Given this list of marker genes St6gal1, Ugcg, Lman1l, H2-Q4, Sdc1, Bet1l, Gga1, Sost, Golt1a, Cav1, Vps37c (NCBI Gene Id 107305), Bicd2, Man2a1, Tmf1, Ccdc88b, Macf1, S100a1, Rab40c, Gorasp1, Hs6st2 (heparan sulfate 6-O-sulfotransferase 2), Golga1, Atp6v0a1, Plpp3, Fut8, Cyp2e1, Creld2, 4930402F06Rik, Axin1, Sipa1l3, Cabp1, Ubxn2b, Gcnt4, Nlrp5, Mphosph9, Clstn2, Tgm4, Galnt18, Prmt5, Yipf5, Slc39a9, Vipas39, Smpd3, Hs2st1, Zfp622, Chek2, Arap1, Syt1, Scamp1, Rab18, Dach1, Lrp2, Fat2, Man1a2, Fam241a, Pals1, A3galt2, Ftcd (NCBI Gene Id 14317), Smo (NCBI Gene Id 319757), Gorasp2, Zdhhc18, B3gnt3, Sncg, Crhbp, Atp8b5, Copg2, Ndst3, Pacsin2, Abca5, Zdhhc7, Atp11a, Cul3, Pcsk4, Scrg1, Golga5, Rsad2, Cd14, Dynap, Clec16a, Ap1s3, H2-M10.3, Gigyf2, Slc66a2, Map2k1, Fam20c, Slc39a7, Srgn, Sdc4, Rab11a, Abca12, Tmed10, Dhcr24, Pde9a, Atp2c1, Mapk1, Nedd4l, Ap1g2, Ndst1, Rab36, Tnfrsf1a, Pick1, Rab6b, Ptprn, Cd33, Ireb2, Plscr2, Tmed11 (NCBI Gene Id 67366), Clvs2, Clcn4 (NCBI Gene Id 12727), Creb3, Zdhhc3, Yipf7, Cd3e (NCBI Gene Id 12501), Otof, Syne1, Nfe2l2, Mal, Fes, H2-T22, Nat8f1, Itm2c, Slc29a3, Tlr6, 1810055G02Rik, Nedd4, Commd9, Apoo, Fam3c, Cd74, Pgap3, Tppp, Clasp1, Nlrp3, A4gnt (alpha-1,4-N-acetylglucosaminyltransferase), Fgf7, Bpnt2, Atp7a, Ccn2, Glt8d2, St6galnac6, St3gal6, Tpte, Ache, Rnd3, Dynlt1b, Six5 (NCBI Gene Id 20475, sine oculis-related homeobox 5), Hs6st1, Mgat2, Pycard, Arl5a, Rab31, Tbc1d4, Map6, Mydgf, Sprr1b, Atl1, Ap3m2, B4galt2, Col26a1, Otor, Gpr108, Pld4, Ddhd2, Ap1s2 (NCBI Gene Id 68960), Aoc3, Dnajc5, Gfy, H2-Q7 (NCBI Gene Id 15018), Ergic1, Vamp5, Atp1a3, Cux1, Dbi, Cptp (ceramide-1-phosphate transfer protein), Prkg1, Taf11, Galnt2, Ppp2r3c, Cracr2a, Perp, Fam20a, Rab33a, Scfd1, Glg1, Myrf, Vamp4, Acsbg1, Mapkap1, Arfgap3, Cdh1, Fgd5 (NCBI Gene Id 232237), B3gnt6, Pea15b-ps, Golga7, Golt1b, Fam114a1, Pla2g4a, Scamp4, Flna, Cldn20, Atat1, Smad6, Capn8, Cav2 (NCBI Gene Id 12390, caveolin 2), Rab40b, Ext1, Rab7b, Sec1, Atp1a1, Rab14, Mmgt2, Golgb1, Usp33, Ap3b2, Gnai3, Mgat4c (MGAT4 family, member C), Mif4gd, Selenoi, Copa, Kif20a, Rab2a, B4galnt1, Rit2, Serpina1c, Chst12, Ap1s1, Smn1, B3gat2, Ccdc170, Chic2, Nbn, Fktn, Stx8, Pkd1, Lrrk2 (NCBI Gene Id 79409), Itm2a, Paqr8, Trappc12, H2-Q1, Rab34, Ms4a6b, Ms4a4b, Rab11fip5, Raf1, Glt8d1, Tas1r3, Gkap1, Rps12, Plekha8, Gal3st2, Gosr2, B3galt2 (UDP-Gal:betaGlcNAc beta 1,3-galactosyltransferase, polypeptide 2), Evi2a, Syt11 (NCBI Gene Id 99745), B3gnt2, Man1c1, Rnf183, Golga7b, Pthlh, Stx16, Scamp3, Zdhhc8, Rhbdd2, Snap25 (synaptosomal-associated protein 25), Chst4, Gimap8, Furin, Entpd5, Arl2, Mmp24, Cog1, Ap1b1, Fyco1, Plekhb1 (NCBI Gene Id 27276), St8sia5, Pex5, Steap2, Rabgap1l, Atp8b2, Tapbp, Pdxdc1, St3gal5, Snx9, Slc26a9, Dnmbp, Rtn3, Dnm1l, Pclo, Slc2a1, Mapk15, Creb3l4, H2-Q2 (histocompatibility 2, Q region locus 2), Mapk3, Rac1, Trappc9, Dnaaf2, Tpst1, Wscd1, Galnt15, H1f0, Wscd2, B4galt7, Spry1, Syt17, Clstn1, Ptges2, H2-M11, Il17rd, Scap, Sgce, Rab1b, Phf7, Aph1b, Marchf1, Extl1, Tbc1d14, Barx2, Gcc2, Cep85, Pcnt, Rab30, Gbp2b (NCBI Gene Id 677276), Serpinb9g, Tgtp2, Chac1, Erc1, Emp2, Tmem98, Gabarapl1, Yipf1, Sppl2b, Slc35a4, Crhr1, Mdga1, Myo1b, Traf3ip3, Ero1a, Mgat1, Jakmip2 (janus kinase and microtubule interacting protein 2), Drd2, Mttp, Zdhhc12, Cbl, H2-T10, Neo1, Nsg1, Mplkipl1, Slc35a3, Pphln1, Arfgap1, Pkd2, Elapor1, Ms4a4c, Lfng, A4galt, Rassf2, B3galnt1, Caln1, Wls, St3gal1, Lmtk2, Tmem30a (transmembrane protein 30A), Myo6, Gask1b (NCBI Gene Id 99844), Chst8, Camk1g, Ubac1, Lyn, Pdgfrb, Fmnl3, Arf6, Rab32, Osbp, Dennd4b, Cop1, Ccdc88a, Rab27b, Trrap, Smpd4, Tvp23b, Birc6, Ppp1r15a, Fgfrl1, Slc35b2, Slc18a3, Tex261, Hs3st5, Nagpa, Vti1a, Cdipt, Chrna3, Slc35c2, Slc24a5, Pkmyt1, Ap1m1, Kif13a, Fut7, Fgfr4, Acp3, Nsfl1c, Ermap, Synrg, Trappc1, Creb3l2, Gpr107, Sec14l1, Kdr, Abcb11, Bcl9, Hdac5, Uxs1, Wdr44, Nedd9, Nmt2, Galntl6, Large2, Gcnt7, Tenm1, Agtrap, Dync2h1, Ndfip1 (NCBI Gene Id 71674), Bicd1, Trappc3l, Sdf4, Serinc5, Paqr4, Yes1, Rab1a, Slc35b3, Nsg2, Chst11, Tmc6, Rasip1, Cog2, Capn2, Lman2l, St6gal2, Atr, Stc2, Gbp4, Rab11fip4, Ndrg2, B4gat1, Inpp5e (inositol polyphosphate-5-phosphatase E), Vamp2, Zdhhc6, Hpd, Ago2, Pacsin3, Galnt17, Optn, Akt3, Dnm2 (NCBI Gene Id 13430), Man2a2, Galnt10, Mapre1, Mettl3 (methyltransferase 3, N6-adenosine-methyltransferase complex catalytic subunit), Serpinb9h, Drd4, Cd2ap, Garin3, Scamp2, Igfbp1, Usp6nl, AU040320, Arhgap21, Ms4a6c, Baiap3, Ap1m2, Garin1b, Asap2, Mmp14, Dpy30, Atp9b, Dym, Pomgnt1, Cog7, Nat8f3 (NCBI Gene Id 93674), Cept1, Gad2, Slc30a6, Rab27a, Pikfyve, B4galt6, Mmd, Rock1, Tsnax, Tjap1, Slc2a4, Srebf2, Sulf2, Jakmip3, Ric1, Gnpnat1, Golm2, Mansc1, Alx1, Ldlrad4, Rab21, Fzd8, Nat8f2, Serpinb9c, Grn, Steap4, Cand1, B3galt6, Mmel1, Clcn5, Aco1, 5730455P16Rik, Sntb2, Ddx54, Sgms2, Stk25, Bace1, Abca6, Bet1, Chst9, Nsf, H2-D1, Copz1, Napepld, Ahsg (NCBI Gene Id 11625), Angptl3, Mta1, Marchf8, Sppl3, Copb1, Camsap2, Ift20, Clta, Zdhhc25, Nubp1, Abcc4, Ipo5, Cit, Kifc3, St8sia3, Prkce, Uso1, Arf2, Pdgfra, Pld1 (phospholipase D1), Selenoh, Fzd5, Cimap3, Alkbh5, Acbd3, Gba2, Cd44, Chrm2, P3h2, Ajuba, Pik3r1, Zfpl1, Atg9b, Gpr89, Ift57, Gnai1, Wasl (WASP like actin nucleation promoting factor), Cln3, Cfp, Gper1, Clspn, Agrn, Vps52, Gdf15, Gdi2, Rheb, Prnp, Amfr, Slc35e3, Srcap, Txndc8, Avpr1b, Trappc6a, Gas8, Dpp7, Inpp5k, Mtor, Scara3, Fndc3a, Blzf1, Chst10, Ergic3, Zdhhc14, Fgfr2, Syndig1l, Slc30a8, H2-Ab1, Trim23, Atf3, Vps45, Cdk13, Zdhhc19, Cabp7, H2-M2, Ptch1, Rab12, Pcsk7, Klhl20, B3galt5, Syn1, Vcpip1, Gcnt2, Chsy1, Nbea, Asic1, Itga5, Unc13b, Aqp2, Gbp2, Pi4k2a, Gcc1, Zfp148, H2-M9, Iigp1, Adcy3, Akap9, App, Pidd1, Stk24, Plekha3, 4933434E20Rik, Gpc5, Pisd, Garin4, Fut2, Ece1, Proc, Pld6, Cpe, Trip10, Fv1, Ptgfrn, Tom1l1, Rab33b, Alb, Gpr143, Plekhm3, Zfyve1, Ccdc91, Slc35c1, Mgat5b, Zdhhc21 (NCBI Gene Id 68268), Ticam2, Gba1, Ap4b1, Clip3, Wdr11, B4galt5, Zdhhc17, Ncs1, Notch2, Cul7, Obsl1, Ap3m1, Fasn, Ece2, Tmem132a, Apoa5, Tmco1, Wipi1 (NCBI Gene Id 74799), Gbgt1, Cd40lg, Rab9, Rapsn, Picalm, Slc35d2, Chst1, Zg16, Pkdcc, Necab3, Cltb, Slc30a7, Ndst4, H2-Q6, Lrp6, Serpinb9, Tmem30c, Sla2, Panx2, Tpst2, Cfap410, Csgalnact1, Tmed9, Usp32, Whamm, Rnf128, Spire1, Tmed2, Slc11a2, Azin2 (NCBI Gene Id 242669), Vcam1, Trim3, Kdelr3, Prkn (NCBI Gene Id 50873), Ap3s2, Vps13b, Ehf, Rab7, Mgat4b, Gal3st3, Itm2b, H2-M10.6, Notch1, Dop1b, B2m, Golga2, Tmed5, Tcp1 (NCBI Gene Id 435546), Apc2, Plod2, Tm9sf4, Litaf, Galnt13, Prcd, Vegfa, Fzd9, Pde3b, Gga2, Itfg2, Tmed6, Glyctk, Tmed3, Lmtk3, St6galnac4, Ggnbp1, Slc30a1, Trpm4, Slc22a13, Arcn1, Slc35g2, Postn, Glce, Hck, Arfip2 (NCBI Gene Id 76932), Hepacam2, Dlg1, Phex, Mapk8ip3, Chst14, Tmem230, Nucb2, Olfm3, Abcc5, Gask1a (NCBI Gene Id 245050), Slc16a13, Ei24, Fam20b, B3galnt2, Msln, Abcb1b, B3gat3, Cst7, Atp8a2, Zdhhc11, B4galnt2, Pofut2 (NCBI Gene Id 80294), Atg9a, Chpf, Hdac3, BC004004, Egfr, Hhat, Tgtp1, Leprot, Tepsin, Galnt6, Tnks2, Sde2, Large1, Gal3st1, Acer3, Hspg2, Ykt6, Cdk20, Fut1, Pmf1, Limk2, Rab8a, Plod1, Pld3, Xylt1, Dclre1c, Lgr5, Dnaaf6rt, Atp8b3, Arl1, Trim7, Slc9a8, Spint2, Zdhhc24, Ap3b1, Bok, Angel1, Resp18, Lpcat2, Il12b, Abca7, Map6d1, Emid1, Cep128, Pmel, Kdelr1, Selenom, Gnaq, Hook3, Nos3, Ganab, Trappc2, H2-M10.2, Gabarap, Fgd1, Vps41, Mpig6b, Atp8b1, Selenok, Rab29, Rnf125, Coro7, B4galt4, Zdhhc23, Cdh15, Pitpnb, Ap4s1, Copg1, Pi4kb, Lztr1, Galnt3, Plagl1, Gpc4, Ptgs1, 4930568D16Rik, H2-M10.5, St3gal3, Irgm1, Tvp23a, St6galnac1, Cubn, Rab3b, Mymx, Tmem241, Polq, Arf1, Tbc1d20 (TBC1 domain family, member 20), Agrp, Has3, Spata16, Asap1, Heatr5b, Gbp3 (guanylate binding protein 3), Clvs1 (clavesin 1), Fut10, Tas2r118, Becn1, Atp2c2, Tgfbi, Adrb2, Scamp5, Mcoln1, Ggta1, Phtf1, Slc30a5, Timm50, Rnf144a, Slc10a7, Extl3, Slc1a6, Trappc8, Mpl, Gpc6, Irgm2, Vapb, Sacm1l, Ldlr, Rab10, Lyset, Cog3, Cideb, Man1a, Prepl, Chp1, Usf1, Tmem130 (NCBI Gene Id 243339), Golga4, Trappc3, Cep83, Pcsk1n, Chst15, Snx17, Pnrc2, Tdrd3, Mosmo, Tmed10-ps, Nat8, Slc39a13, Qpctl, Naa25, Gkn2, Marchf2, Lgi1, Chst3, Elmod3, B3gnt7, Rhbdf1, Chst7, Elmod1 (NCBI Gene Id 270162), Rab38, Hs3st2, Hook2, Arhgap32, St3gal4, Mr1, Rras2, Lpcat1, Svip, Lrp1 (low density lipoprotein receptor-related protein 1), Yipf2, Stx6, Mink1, Tmem167b, St8sia1, Llgl1, Plk3, Rxylt1, Tmem87b, Scyl1, Sgsm1 (small G protein signaling modulator 1), Stx5a, Clcc1, Myoc, Kif1c, Dusp26, Trappc4, Sdc2, Pacs1, Plscr1 (phospholipid scramblase 1), Arl3, Enpp7, Stk16, Syndig1, Vps51, Pdyn, Cltc, Rhobtb3, Zdhhc20, Cxcl14, Sec22b, Igf2r, M6pr, Gbp5, Cts7, Gnptab, Ctnna1 (catenin alpha 1), Apc (NCBI Gene Id 11789), Osbpl9, Trappc5, Chst5, Lrba, Snap29, Rmdn2, Nat8f5, Jam3, Pwp1, Sec23ip, Clcn3, Sart1, Strn3, Sybu, Paqr3, Actr3, Ihh, Acsl3, Tmbim7, Rab26, B3gnt9, Cln5, Maneal, H2-M5, Tenm2, Abcg1, Tgfb2, Treml1, Serpina1e, Scyl2, Serinc3, Mid1, Nod2, Bdkrb2, Chpf2, Ier3ip1, Csgalnact2, Copz2, Slc35a5, Ocrl, Pcsk5, St8sia2, Cnst, Plekhj1, Trappc13, Galnt5, St6galnac2, Lman1, Tmbim4, H2-Q10, Gimap1, Mmd2 (NCBI Gene Id 97274), Galnt14, Cog8, Zdhhc9, Garin5a, Tm9sf2, Mppe1, Entpd7, Mall, Sptbn2, Arf4, Arfip1, Clint1, Faim2, Bst2, Cog4, Rhou, Cpq, Vtn, Fgf3, Galntl5, Emc8, Kifap3, Ripor1, Rnf148, Has1, B3galt4, Birc7, Stx4a, Plod3, Mbtps2, Rbfox1, Slc35e4, Fam234b, Ap3s1, Cope, Spp1 (NCBI Gene Id 20750), Atp8b4, Tmem209, Gcnt1, Abcb6, Serpina1a, Tnfrsf10b, Mmgt1, Pitpnm1, Rtn1 (NCBI Gene Id 97843), Abcb4, Adam10, Naa60, Naa11, Cripto (cripto, EGF-CFC family member), Serpinb9f, Plce1, Ms4a4a, Map4k2, Trp73, St3gal2, Rfng, Pheta2, Sar1a, Rab37, Prkd2, Clba1, Sorl1, Gapt, Bcap31, Mamld1, Sort1, Slc38a10, Atp9a, Gabarapl2, Esco2, Golph3, Ms4a6d, Rad23a, Glb1, Psenen, Galnt4, Ebag9, Eef1ece2, Grb2, B4galnt3, Lax1, Tango2, Ap3d1, Gdnf, Ap1ar, Ash1l, Mapk10, Bace2, Pheta1, Sar1b, Golm1, Prdm2, Yipf3, Scyl3, Tnks, Fkrp, Sprr3, Galnt12, Prss59, Tbc1d22a, Nucb1, Cnih1, Fgfr3, Hras, Snapin, Fbxw8, Dnm1, Spef2 (NCBI Gene Id 320277), Esr1, Tbc1d23, Garin1a, Trappc6b, Bmp1, Gdi1, Gpc3, Uba5, Ctla4, Parp10, Cntnap2, Eipr1, Mcfd2, Clasp2, B3gnt5 (UDP-GlcNAc:betaGal beta-1,3-N-acetylglucosaminyltransferase 5), Dhh, Dse, Htt, Rab39b, Gcnt3, Dysf, Rusc1, Sema6d, Tbc1d5, Agbl4, Wdr77, Lap3, Mlana, Apbb2, Arfgap2, Dapk2, Slc30a10, Dbnl, Ndfip2, Creb3l1, Slc35b4, Atp11b, Rp2, Zdhhc16, Rnf133, Map2k2, Coq6, Gpc1, Pgap4, Vgf, Abo, Marf1, Nlgn1, Spring1, Nmnat2, Cd36, Car4, Trim68, Myo5a, Slpi, Tgoln1, Fam91a1, Nhs, Arl5c, Aplp1, Psmg1, Pskh1, B3galt9, Pja2, Grina, Kel, Fut4, 2410002F23Rik, Pcgf5, St6galnac3, Parm1, Zdhhc4, Arfgef1, Huwe1, Vps33b, Rgs20, Gnas (GNAS complex locus), Mbtps1, Vapa, Cog5, Ncstn, Slc39a11, Slc35b1, Rab11fip3, Stx12, Gopc, Tmem167, Gkn1, Naa12, Sh3glb1, Pkhd1, Atxn2, Serpina1b, Sfta2, Hs3st3a1, B4galt3, Arf3, Pde2a, Vps54, Vps53, Galnt11 (polypeptide N-acetylgalactosaminyltransferase 11), Lypla2, Hs3st1, Hs3st3b1, Camkmt, Unc45a, Rab2b, Gorab, Rpgr, Ap1g1, Slc50a1, Vti1b (vesicle transport through interaction with t-SNAREs 1B), Cntrl, Gnptg, Rnf149, Slc35a1, St8sia4, Hyal2, Xylt2, Cog6, Arhgap33, Serpinb9b, Cep162, Serpinb9e, Gosr1, Asah2, Malrd1, Sec23a, Hip1, Hid1, Tmem45b, Fgf22, Rnf122, B3gat1, Nipal1, Mroh4 (NCBI Gene Id 69439), Fut11, Rab6a, Tmem214, B3galt1, Fcmr, Dennd4c, Pmepa1, Ift88, Syt4, Ucma, Gak, Rab25, Npc1, Pxylp1, B3gnt4, Galnt7, Slc35d3, Tsc2, Arfgef2, Aimp1, Tmed4, Atp8a1, Unc50, Slc35e1, Aftph, Napg, Cabp2, Tlr2, Kdelr2, Golim4, Rho, Galnt9, Rer1, Stmn3, Rnf24, Hspd1, Slc26a11, Entpd4b, Sys1, Lysmd3, Ubxn2a, Gpc2, Elane, Chsy3, Marchf9, Cttn, Entpd4, Actl7a, Tmem87a, Pcsk9, Armh3, Tmem50b, Csde1, Stx11, Ica1l, Zdhhc22, Mplkip, Tmem79, Sh3rf1, Cspg5, Scoc, Cd247, Cst3, Zdhhc2 (NCBI Gene Id 76202), Mgat3, Ift27, Clic5, Bcl6, Ppt1, Kbtbd8, Tmem30b, Prkaa2, Opalin, Slc9a7, Yif1b, Mtus1, Sdcbp2, Cpd, Trappc2l, Hs6st3, H2-T3, Exoc3, H2-M10.1, Sdc3, Gja1, Fbxw7, Rabep2, B4galnt4, Sec16b (SEC16 homolog B, endoplasmic reticulum export factor), Cdc42, Serpinb9d, Surf4, Laptm4a, Galt, Ndst2, Shh, Syap1, Galnt16, Rab22a, Srebf1, S100a3, Ctsl, Creg2, Gga3, Nras, Lat, Trappc11, Mgat5, Myo18a, Cdk5rap2, Cant1, Casd1, Samd8, Tmed7, H2-M10.4, B3gnt8, Tmem43, Vps13a, Ttc3, Csnk1d, Pik3c2a, Snx1, Trappc10, Myh9 (NCBI Gene Id 97972), Cav3, Zdhhc13, Ext2, Rasgrp1, Slc35a2, Trappc14, Dynapl1, Zdhhc1, Sting1, Mgat4a, Lamp2, Akr7a5, Atf6, Tmc8 (NCBI Gene Id 276788), Rgp1, Cd2, Lyz2, Nlrp2, Rab11b, Scly, Psen2, Mgat4d, Mtcl2 (NCBI Gene Id 98949), Ica1, Rab20, Trip11, Rab3gap1, Cep57, Tbc1d1, Ppp2r5c, Mme, Cbln3, Tnrc6a, Hace1, Pla2g5, Colec10, Stk26, Cerkl, Atp7b, Ust (NCBI Gene Id 338362), Prrc1, Pacsin1, Wdfy1, Pam, Acer2, Retreg1, Chpt1, Prkd1, Tpp1, Tapbpl, Gpsm1 (NCBI Gene Id 99317), Ntsr2, Cert1, Sorcs1, Il12a, Mpp4, Chid1, Golph3l, Lrpap1, St6galnac5, Pde4dip, Tbc1d31, Fhdc1, Tmem59l, Inppl1, Glipr2, Elf3, Ap4e1, Prkci, Tmem165, Arv1, G2e3, Klf5, Dpagt1, Gsap, Tlcd3b, Adam19, Igtp, Ptgds, Spag17 (sperm associated antigen 17), Gbf1, Sod3, Npy, Glt6d1, Pgap2, B4galt1, H2-M3, Cby1, Rab43, Psen1, Fut9, Cbfa2t3, Bsn, Lyz1, Pdcd10, Phaf1, H2-K1, St8sia6, Agtr1a, Abca1, Kcns3 (potassium voltage-gated channel, delayed-rectifier, subfamily S, member 3), Arl5b (NCBI Gene Id 99340), Qsox1 (NCBI Gene Id 66883), Zdhhc15, Mob4, Hs3st6, Arhgef2, Tbc1d22b, Tmbim1, Gh, Vrk1, Entpd6, Ms4a7, Sec16a, Dennd5a, Ddx31, Sgpp1, Clstn3, Gfra1, Tlr1 (NCBI Gene Id 21897), Tmem59, Tmed1, Ubiad1, Copb2, Rnf115, Mospd1, Lman2, Calu, Rnf121, Lipg, Dipk2a, Faah, Yipf6, Arf5, Aph1a, Qsox2, Ntn3, Mymk, H2-M1, Tmem115, Has2, Msh6, Rap1gap, Apba1, Apoe, Golga3, Gla, Ap4m1, Arfrp1, Fez1, Rab13, Ccdc186, Dock4, Tent4a, Ltbr (lymphotoxin B receptor), Sulf1 (NCBI Gene Id 98668), Stx18, Stmn4, Yipf4, Osbpl11, Slc35e2, Sun5, Serpina1d, Slc35d1, Stmn2, Fibin (NCBI Gene Id 67606), Manea, Rabac1 (NCBI Gene Id 80486), Marchf4, Mfng, Dnaaf6, Grm6, Relch (RAB11 binding and LisH domain, coiled-coil and HEAT repeat containing), Bend5, Dop1a, Pi4k2b, Wwox, Yif1a, Galnt1, Chst2, Ergic2, Fam174b, Sgms1, Dram2, Kcnip3, Ms4a4d, Pcsk1, here is a description of the gene set: A membrane-bound cytoplasmic organelle of the endomembrane system that further processes the core oligosaccharides (e.g. N-glycans) added to proteins in the endoplasmic reticulum and packages them into membrane-bound vesicles. The Golgi apparatus operates at the intersection of the secretory, lysosomal, and endocytic pathways. species: Mus musculus Mouse Gene Set: GOCC_GOLGI_APPARATUS